The following is a description of a gene set: studied in species Mus musculus Mouse Gene Set: GOBP_FRUCTOSE_METABOLIC_PROCESS The chemical reactions and pathways involving fructose, the ketohexose arabino-2-hexulose. Fructose exists in a open chain form or as a ring compound. D-fructose is the sweetest of the sugars and is found free in a large number of fruits and honey., and this is the list of marker genes: Aldoa, Sord, Tkfc, Pfkfb2, Akr1b1, Aldob, Fbp1, Gnpda1, Pfkfb4, Glyctk, Aldh1a7, Aldh1a1, Khk, Pfkfb1, Fbp2